Given this list of marker genes Fgfr3, Rrm2, Taf3, Mbnl2, Dnajc27, Tead1, Stmn2, Moap1, Zscan20, Rbl2, Tbr1, Nid1 (NCBI Gene Id 268621), Khdrbs2, Ppat, Herc4, Nt5e, Bpnt2, Ccdc171, Ro60, Zbtb21, Arhgef3, Gnl3, Cd247 (CD247 antigen), Phactr2, Sema3a, Gpm6a, Kctd12 (potassium channel tetramerisation domain containing 12), Tmprss11f, Btbd35f18, Btbd35f14, Usp3, Gemin2, Wac, Pi4k2b, Btbd35f7, Rp2, Gbp9 (NCBI Gene Id 236573), Kdm5a, Yod1, Ube2a, Ube2j1, Cnr1, Col4a3, Ankra2, Tab3, Ccdc125, 4930579G24Rik, Osgin2, Mbnl3, Rbfox1, Apob, Zfhx4, Cacna1b, Btbd1, Mei4, Khdrbs1, Acyp1, Pabir1, Osbpl8, Aasdhppt, Marf1, Ankrd42, Gbp10, Btbd35f13 (NCBI Gene Id 100040722), Ipo5, Rai14, Zfp148, Plekhg1, Btg1, Eftud2, Cdk19, Nusap1, here is a description of the gene set: Mouse Gene Set: MIR_7217_5P species: Mus musculus Genes predicted to be targets of miRBase v22 microRNA mmu_miR_7217_5p in miRDB v6.0 with MirTarget v4 prediction scores > 80 (high confidence targets). from publication Chen Y, Wang X (PMID 31504780)